The following is a description of a gene set: studied in species Homo sapiens from publication Hale JS, Youngblood B, Latner DR, Mohammed AU, Ye L, Akondy RS, Wu T, Iyer SS, Ahmed R (PMID 23583644) Genes down-regulated in CD4 SMARTA effector T cells during acute infection of LCMV: Th1 versus follicular helper (Tfh). CD4 T follicular helper (Tfh) cells provide the required signals to B cells for germinal center reactions that are necessary for longlived antibody responses. However, it remains unclear whether there are CD4+ memory T cells committed to the Tfh lineage after antigen clearance. Using adoptive transfer of antigen-specific memory CD4+ subpopulations (based on CXCR5 and Ly6c expression)in the LCMV infection model, we found that there are distinct memory CD4+ T cell populations with commitment to the Tfh and Th1 lineages. Our conclusions are based on gene expression profiles, epigenetic studies and phenotypic and functional analysis. The gene expression profiles of virus-specific CD4 T cell subets at effector and memory stages is presented here. Human Gene Set: GSE43863_TH1_VS_TFH_EFFECTOR_CD4_TCELL_DN, and this is the list of marker genes: KDM3A, ST8SIA6, ARHGEF1, FBXL20, RANBP2, MEF2A, TRIO, CARD6, MEF2B, KLF13, SMIM14, ATP10D, CAMK4, TAGLN, TBC1D15, MIB2, MEPCE, CCR7, PAIP2, KIF21B, ACP6, DNM2, CAMK1D (NCBI Gene Id 57118), RAB12, SLPI, RPS14, USP24, LTB, OTULINL, SHISA5, YPEL3, LDB1, ANGPTL1, USP33, RAB20, KCNAB1, SLC50A1, PNPLA6, WDR44, TTC19, MTSS1, HABP4, SLC35B3 (solute carrier family 35 member B3), ZRANB1, TEX264, ABTB3, SIRT7, PBX1, MAP3K14, POLG, SUSD6, PDE1B, CTDSP2, TTBK2, TNS3, CD27, WNT5B, CARNS1, BACH1, FAM117A, H2AC25, TMEM87B, MPPE1, MBTPS1, KDM7A, FGF13, RGS14, ACAP1, BRWD1, MZB1, GRAMD2B, RASSF3, SPOP, TMEM269, PARP6, CD37, ERC2, EXD1, CNST, ATP1B1, DCAF11, RAB33B, SCG5, SLC49A4, SF3B1, TRAPPC8, ETV3, CNN3, RHOT1, SNX15, RABEP1, NCLN, VPS26A, FHIP1B, CBX7, GMIP, C1orf52, TMX4, FCHSD1, PIGP, PITPNM1, HNRNPH1, BAZ2B, FOXP1, HSD17B11, KIZ, KREMEN1, HBP1, PLEC, SMAD4, HSF1, ARHGAP4, RAB3IP, PARP4, INSR, ZNF236, NR2F1, WDR82, PIK3CA, SIDT1, OSBPL7, GPRASP1, EEIG2, AP2A2, SELENOP, FOXO4, H3C14, TCP11L2, ZMYM2 (NCBI Gene Id 7750), COL9A3, RNF146, CRLF3, ZBED6, ITPRID2, SH3PXD2A, INVS, SFXN3, TPRG1L, EDRF1, LAT, RASGRP1, SUN2, PIP5K1C, IL17RA, SERPINI1, TNRC6C, IGLC7, PRKCE, CPM, WASHC2A, ATOSA, TMEM63A, SERAC1, PNPLA7, CTPS2, NUFIP2, RFX1, CDIPT, UBP1, RSBN1, TMLHE, RAB11FIP2, HECA, MITF (melanocyte inducing transcription factor), CDC14B, THEM4, PPDPF, LMBR1L, BCL7B, FCGRT, ZNRF1, LBH, IRF2BPL, FAM234B, ACBD5, SAT1, SENP7, UPK3BL1, GPR132, C4orf19, ENTREP3, SEZ6, TOM1, HERC2, LRRC23 (NCBI Gene Id 10233), ARID1A, TRIM65, ITPRIP, RIPOR1, IP6K1 (inositol hexakisphosphate kinase 1), STK10, HLA-DOB, CLOCK, SEC62, STK17B, RAP1GDS1, FRYL, ZFP28, RHOH, CREBBP